Given this list of marker genes PSMB1, TACC3, PSMD12, PSMC1, PSMA1, PSMA6, PSMA7, PSMD8 (NCBI Gene Id 5714), FBXW7, PSMD2, UBA52, PSMD14, SKP1, ADRM1, PSMC4, YWHAZ, UBC, PSMD11, PSMB2, NOTCH4, PSMD7, PSMB5, PSMD13, PSMD1, UBB, PSMC6, PSMD6, AKT1, PSMC5, CUL1, RBX1, PSMA4, PSMB4, SEM1, PSMB6, RPS27A, PSMC2, PSMA2 (proteasome 20S subunit alpha 2), PSMB7, PSMA5, PSMB3, PSMD3, PSMC3, PSMA3, here is a description of the gene set: species: Homo sapiens NOTCH4 signaling can be negatively regulated at the level of nuclear translocation of the NOTCH4 intracellular domain fragment (NICD4). AKT-mediated phosphorylation of NICD4 promotes binding of NICD4 with 14-3-3-zeta (YWHAZ), leading to retention of NICD4 in the cytosol.<br><br>The E3 ubiquitin ligase FBXW7, a component of the SCF ubiquitin ligase complex, binds to and ubiquitinates phosphorylated NICD4, targeting it for proteasome-mediated degradation. The level of NICD4 is significantly increased in Fbxw7 knockout mouse embryos, which die in utero and have impaired development of the vascular system.<br><br>Binding of NOTCH4 to ELOC (elongin C) is involved in proteasome-mediated degradation of NOTCH4, but the exact mechanism has not been elucidated. MDM2, a TP53-induced ubiquitin ligase, was reported to ubiquitinate NICD4 and target it for degradation in response to TP53 activation.<br><br>NOTCH4 signaling is inhibited by binding of NICD4 to the transforming acidic coiled-coil protein-3, but he mechanism is not known. Reactome Pathway: Negative regulation of NOTCH4 signaling part of: Signaling by NOTCH4